Given this list of marker genes Fos, H1f2, Jund, Klf2, Stk17b, Rhob, Zfp36, H3f3b, Tsc22d3, Junb, Uba52, Btg1, Ier2, Klf6, Fosb, Cxcr4, Dusp2, here is a description of the gene set: Genes negatively differentially expressed in cell type: B cell upon treatment with cytokine: EGF in mouse lymph nodes in vivo. Cytokines mediate cell-cell communication in the immune system and represent important therapeutic targets. A myriad of studies have highlighted their central role in immune function, yet we lack a global view of the cellular responses of each immune cell type to each cytokine. To address this gap, the authors created the Immune Dictionary, a compendium of single-cell transcriptomic profiles of more than 17 immune cell types in response to each of 86 cytokines (>1,400 cytokine-cell type combinations) in mouse lymph nodes in vivo. A cytokine-centric view of the dictionary revealed that most cytokines induce highly cell-type-specific responses. For example, the inflammatory cytokine interleukin-1β induces distinct gene programmes in almost every cell type. A cell-type-centric view of the dictionary identified more than 66 cytokine-driven cellular polarization states across immune cell types, including previously uncharacterized states such as an interleukin-18-induced polyfunctional natural killer cell state. species: Mus musculus from publication Cui A, Huang T, Li S, Ma A, Pérez JL, Sander C, Keskin DB, Wu CJ, Fraenkel E, Hacohen N (PMID 38057668) Mouse Gene Set: CUI_B_CELL_EGF_RESPONSE_DN